Given this list of marker genes RAD51, CALR, ATP1A2, ATP1A3, ABCB1, ATP1A1, CHEK2 (checkpoint kinase 2), here is a description of the gene set: Any process that results in a change in state or activity of a cell or an organism (in terms of movement, secretion, enzyme production, gene expression, etc.) as a result of a glycoside stimulus. studied in species Homo sapiens Human Gene Set: GOBP_RESPONSE_TO_GLYCOSIDE